Given this list of marker genes Cbl, Ctf1, Cntfr, Jak2, Osm, Il11, Lif, Crlf1, Il31ra, Clcf1, Il11ra1, Cntf, Il6, Lifr, Il31, Stat3 (NCBI Gene Id 68733), Il6st (NCBI Gene Id 71317), Tyk2, Socs3, Ptpn11, Osmr, Il6ra, here is a description of the gene set: Interleukin-6 family signaling Mouse Gene Set: REACTOME_INTERLEUKIN_6_FAMILY_SIGNALING studied in species Mus musculus